The following is a description of a gene set: Human Gene Set: MULLIGHAN_MLL_SIGNATURE_2_DN Somatic mutations in nucleophosmin (NPM1) occur in approximately 35% of adult acute myeloid leukemia (AML). To assess the frequency of NPM1 mutations in pediatric AML, we sequenced NPM1 in the diagnostic blasts from 93 pediatric AML patients. Six cases harbored NPM1 mutations, with each case lacking common cytogenetic abnormalities. To explore the phenotype of the AMLs with NPM1 mutations, gene expression profiles were obtained using Affymetrix U133A microarrays. NPM1 mutations were associated with increased expression of multiple homeobox genes including HOXA9, A10, B2, B6 and MEIS1. As dysregulated homeobox gene expression is also a feature of MLL-rearranged leukemia, the gene expression signatures of NPM1-mutated and MLL-rearranged leukemias were compared. Significant differences were identified between these leukemia subtypes including the expression of different HOX genes, with NPM1-mutated AML showing higher levels of expression of HOXB2, B3, B6 and D4. These results confirm recent reports of perturbed HOX expression in NPM1-mutated adult AML, and provide the first evidence that the NPM1-mutated signature is distinct from MLL-rearranged AML. These findings suggest that mutated NPM1 leads to dysregulated HOX expression via a different mechanism than MLL rearrangement. from publication Mullighan CG, Kennedy A, Zhou X, Radtke I, Phillips LA, Shurtleff SA, Downing JR (PMID 17597811) The 'MLL signature 2': genes down-regulated in pediatric AML (acute myeloid leukemia) with rearranged MLL compared to the AML cases with intact MLL and NPM1. studied in species Homo sapiens, and this is the list of marker genes: SMIM8, NAA16, EDN2, FAAP20, CYP4F2, KIR3DL2, MSMB, FAM171A1, COPG2IT1, ICOSLG (inducible T cell costimulator ligand), GSDMB, PML, DAPK1, HINT1, MCF2L, METAP1, CYP2E1, NIT2, MACIR, MYRF, LGR5, LUZP1, RPS6KA2, ARFGEF1, TMEM268, SCN2A, ATP2C1, NPM1, OLA1 (Obg like ATPase 1), TBXA2R, SLC7A1, PPL, RBPMS, TPD52, POU4F1, LAX1, NONO, STAP1, RANBP2, DNAH2, MAPRE2, SLC17A9, LRRC8B, MROH7, DNAJC12, ITM2A, MAST4, BAALC, HMGN4, ZNF16, LGALS3BP, CSAD, NET1, EGFL7, WDR59, ABCC4, APP, HYAL2, MN1, MUC4, RPP40, SPRY1 (sprouty RTK signaling antagonist 1), TGFBRAP1, PTP4A3, GTPBP1, TNFRSF21, CHD1L, BTN3A3, RIPOR1, PITPNB, NME4, LEPROTL1, USP34, AP1B1, CERS4, SLC12A4, HSD17B12, CEP170, TGFB1I1, STAT5A, CETP, EIF2AK2, VAV3, KRTAP5-8, KMT2A, HNRNPA1, CXCL8, CYTL1, IFI16, WWC3, MANSC1, SUPV3L1, MRPS2, EEF1D, CD96, CD3D, ENDOD1, MGAT5, YES1, PLSCR3, ITGAV, MRC1, ATP2A3, CLIC4, ARAP2, CD1E (CD1e molecule), SINHCAF, NPR3, OLFM4, RAB11A, GNPTAB, IFI44, MDK, NBL1, CKB, RASL10A, B4GALT6, DUSP14, P2RX3, H1-0, KIFAP3, DPT, PGF, TNFRSF4, ATP2A2, GGT5, TNPO2, TSPAN7, PMAIP1, IER2, DAB2, RPL36, RALGDS, SEPTIN11, GALNT1, CLMN, BTG3, CTDSPL, TM4SF1, LOXL1, DYNLL1P3, SLC18A2, BRD8, KTN1, IFITM1, TRIM16, N4BP2L2, DLEU1, PRKCQ, TRH, TFPI, FDFT1, TRIM24, LHFPL2, LYRM1, TIE1, STAT4, LINC01963, CSN3, EPS15, NTRK2, HS2ST1, PPP1R16B, STK32B, STAM, TTC3, KATNB1, ADRM1, DEPTOR, FGFR1, SORL1, LRRN2, MAN1A1, SIPA1L1, EGR3, LAMA5, CAVIN1, IL2RA, SERP1, PTGIR, HGF, JAK1, CD200, CCNG1, DCUN1D4, DHRS3, MMP2, ACACA, MYH11, HIP1R, HPGDS, PTPN14, PRF1, ABCB1 (ATP binding cassette subfamily B member 1), CDH16, HPGD, SYNCRIP, PTPRCAP, SEPTIN9, ANKLE2, CD99, PIGP, ELMO1, ATRX (NCBI Gene Id 6475), PYCR1, MYO5C, TEX11, DNTTIP2, SMYD2, LAMC3, ADK, ST18, HACD1, VGLL4, RHOH, SESN1, MRPS22, RUNX1, DBN1, TRMT1, FSCN1, TNFRSF25, SPARC, ABHD10, CD34, TEX10, BCAT1, LAMB2, EFCAB6, ATP1B1, ZNF544, GLS (NCBI Gene Id 51679), MPL (MPL proto-oncogene, thrombopoietin receptor), PDIA5, ZNF85, TEAD4, MATR3, KHDRBS1, HNRNPA1P3, RUNX1T1, TGFBR2, STAT5B, HIF1A, AREG, DMXL1, SRI, PRKCH, MACF1, CDH4, STOM, PEX3, BAIAP3, CXCL2, MCTP2, SLC24A3, AGRN, NEDD4, BARX2, NR2F2, HEMK1, GTPBP3, NUDT11, ISOC1, KLRK1, UBR5, FAH, PDCD4, KDM5B, CHI3L1, PTHLH, NUP50, ASS1, POLE, ASXL1, NHERF2, UBE2E1, WASF1, SERPINE2